The following is a description of a gene set: Genes up-regulated in macrophages (12h): control versus rosiglitazone and IL4. from publication Szanto A, Balint BL, Nagy ZS, Barta E, Dezso B, Pap A, Szeles L, Poliska S, Oros M, Evans RM, Barak Y, Schwabe J, Nagy L (PMID 21093321) Human Gene Set: GSE16385_UNTREATED_VS_12H_ROSIGLITAZONE_IL4_TREATED_MACROPHAGE_UP species: Homo sapiens Human CD14 positive monocytes were purified from healthy volunteers’ blood and cultured in vitro for 4, 12, 24, 72 hours. While culturing, macrophages were activated alternatively with interleukin-4 (IL-4 100 ng/ml) or classically with interferon-gamma (IFNg 100 ng/ml)+tumor necrosis factor (TNF 50 ng/ml) or left without activation. Simultaneously, macrophages were also treated with vehicle (DMSO:ethanol) or 1mM synthetic PPARg agonist, Rosiglitazone. We used Affymetrix microarrays (U133Plus 2.0) to analyze activation and PPARg-induced gene expression changes., and this is the list of marker genes: CBLB, ALG9, ETF1, LMNB1, SOX4, CHKB, FGFR1OP2, CCR7, LZIC, ZCCHC8, MGAT2, JUP, FBXL3, RAB5C, SSBP3, RAB37, GPX4, SUDS3, PNN, CFAP141, DDX19A, SHC1, PDIA3, ZNF395, ITGA5, PPP4C, CNOT3, SUOX, CEP250, TP53RK, STK24, CDKN1A, SLC25A39, TRIP10, ROPN1L, BCL2L12, FHOD1, TNFSF10, AKT3, MSL2, STK25, SIAH2, RARA, RBM22, ITGB1, MAX, RBP7, CYRIA, QRICH1, RAPGEF3, TGIF1, IFITM3, PABPC4, PLEKHJ1, SLC29A3, ARF5, NYAP1, ZNF652, CDC42EP3, CFL1, ZNF131, ARHGAP17, ERP29, MRI1, SLC9A9, PRAMEF8, REG3G (NCBI Gene Id 130120), TBC1D22B, MAZ, ANKRD16, IFNGR2, B3GNT2, RCC2 (regulator of chromosome condensation 2), HSPBAP1, AKNA, DLG4, PNISR, LIPE, RMC1, SLC25A51, ZBTB25 (NCBI Gene Id 7597), LETMD1, RAB11A, ICA1, ANKRD13D, CIMAP1B, POP4, GLYR1, NKAPD1, PARP8, TRIM11, WDR83OS, DTX3, SF3B4, UBTF, SPINDOC, KLHL36, MRPS24, SEPTIN9, ATP11A, AMFR, AP2B1, CACNA1A, PER1, ALG2, KBTBD2 (kelch repeat and BTB domain containing 2), PBX2, PA2G4, GPR146, MTURN, PPARD (NCBI Gene Id 5467), RTL8B, TUBE1, NSMCE3, PTPN6, HLA-E, KCTD1, DDOST, MDM4, SENP2, ARHGEF2, TOX, CAMK2D, PFN1, LIN7C, SLC25A23, PIGM, TTC5, ANXA5, PPDPF, ABHD1, EEIG1, CHRNE, EPB41, GPR132, NF1, NMNAT1, RASGRP4, PPP1R3B (NCBI Gene Id 79660), NCSTN, STRIP1, ATF4, SEMA4D, KDM3B, EDEM1, IFNGR1, EIF5A, SLC39A7, RNF167, METRN (meteorin, glial cell differentiation regulator), MAN1B1, APBB1IP, UBE4B, LTA, SNRNP70, PHPT1, DGKQ, NAB2, IRAK4, TSC22D3, EVL, MKNK2, SLC16A1, PSME3, ATP5F1B (ATP synthase F1 subunit beta), ZNF362, STAC3, PRR14, CHIC2, PAFAH1B2, APOBEC3B, GIMAP6, LSM2, BCAT2, WDR1, ELF2, RAB11FIP3, PLEKHO1, FMNL1 (formin like 1), SMNDC1, NPM3, CEP170, SETD5, CTNNBIP1, COQ10B, UTP15, SNAP29 (NCBI Gene Id 9342), STAT5B (NCBI Gene Id 6777), GIGYF2, RHOA, FRG1, TAPBP, TLE3, EPCAM, CYTH1, JUNB, CCDC85B, IL17RA, TLE1, WDR45B (WD repeat domain 45B)